Given this list of marker genes GJB4, BMP5, LSS, TMEM38A, PPP2R5D, UNC45A (unc-45 myosin chaperone A), C2, EZR, MMP15, AOC1, METTL13 (NCBI Gene Id 88158), RASL10A, NDUFV3, TMEM54, GCH1, KCNJ9, PRKN, CASP3, ESM1, TIMP2, EMD, MS4A6A, HSPA2, INSL5, SYTL3, AGFG1, UBE2L3, PPEF2, SEC24D, LRR1, BCAT1, KRTCAP3, DENND2D, KRTAP20-2, PITHD1 (PITH domain containing 1), GZMA, BHLHE40, SERPINB5, BCL11B, SLCO1A2, TECTA, POLM, CASP6, CNTNAP4, CD3G, ADIPOQ, TLL2, POU2AF1, NEK8, LRRC20, MED20, MYH2, COL12A1, FBXL12, CD3D, POLD1, CACNA1B, IL2RA, IPO4, MPZL2, TUBB2A, PLA2G12B (phospholipase A2 group XIIB), GAD1, COL6A3, FAM118B, TEX15 (testis expressed 15, meiosis and synapsis associated), MTRES1, PUDP, CLEC11A, NPY, ARHGAP24, TMEM120B, MAP7D1, EREG, YBX2, LBX1, TXK (NCBI Gene Id 7294), GRAP2, IZUMO1R, FOXP3, SELL, MYH4, HRG, NDRG2, SLFN12, GAL, CCDC70, LPXN, IRS1, KRTAP3-3, PARP16, CHML, BHLHE22, GRB7, XBP1, METTL8, MOV10L1, PGAM2, ZNF14, AGAP2, CNDP2, RAB27A, CTSE, TOM1L1, HAO1, FYB1, PPARA, TFIP11, TEDC1, ELF4, EPHX2, TMEM63B, DEGS2, FBP1 (NCBI Gene Id 2203), ADAMTS8, H19, PLD4, RGCC, PRKCA, MLX, MYL10 (NCBI Gene Id 93408), CD3E, GAB3, PKP2, ORM2, PEX6, GCOM1 (GCOM1, MYZAP-POLR2M combined locus), SLC4A10, TRAT1, CLBA1, SELENOS, RAG2, TEAD3, TUBB3, CD27-AS1, EDARADD, GDPD1, PODXL, SLC2A4, PKP3, DDIT4L, CXCR4, CTSK, PDCD1, HPCAL1, NHERF4, CREB3L3, GNG12, KRTAP19-5 (keratin associated protein 19-5), G0S2, TUBB2B, DNAJB2, KHDC1L, TECPR1, GPX8, REC8, KRT25, PRELP, LGR6, ANXA2, MST1R, DHX40, POU6F1, ADAM2, AHDC1, S100A9, MPP1, GTSE1 (G2 and S-phase expressed 1), PLPP1, SPINT2, CD247, PPARG, NCK2, TAS1R1, ADRB2, PRPS2, GALNT3, RRAS2, TMEM214, THY1, CRYGN, NEU2, BASP1, MFSD4A, C3orf70, MCUB, LGALS1, GCM2 (NCBI Gene Id 9247), GADD45G, PTCRA, PPP1R11, PTPN13, MSH4, CASP12, SPIB, ASAH2, RHOV, MCAM, MCOLN2, SEC61B, here is a description of the gene set: Development of T-cells provides a unique opportunity to study cell-fate determination due to the accessability and the well defined stages of developmental stages. In order to understand the genetic programs underlying fetal and adult T‑cell fate specification we subjected highly purified fetal and adult T-cell progenitor populations to a genome‑wide transcriptional analysis. The aim was to identify molecular elements that govern T-cell fate specification as a whole but ultimately to isolate elements that were specific for a given population in a specific developmental window. Genes down-regulated in comparison of thymic progenitors versus fetal DN2 thymocytes. Human Gene Set: GSE24142_EARLY_THYMIC_PROGENITOR_VS_DN2_THYMOCYTE_FETAL_DN from publication Belyaev NN, Biró J, Athanasakis D, Fernandez-Reyes D, Potocnik AJ (PMID 22581009) species: Homo sapiens